Given this list of marker genes Pole, Apc, Il10, Tnk1, Gnai2, Smad3, Muc2, Ppard, Rassf1, Msh2, Itgav, Bub1b (NCBI Gene Id 99239), Pold1 (polymerase (DNA directed), delta 1, catalytic subunit), Mlh1, Msh3, here is a description of the gene set: Mouse Gene Set: MP_INCREASED_INTESTINAL_ADENOCARCINOMA_INCIDENCE from publication Motenko H, Neuhauser SB, O'Keefe M, Richardson JE (PMID 26092688) Mouse genes annotated to increased intestinal adenocarcinoma incidence (MP:0002957) retrieved from the Mouse Genome Informatics database via MouseMine studied in species Mus musculus